Given this list of marker genes PCED1B, HDAC9, ACKR3 (atypical chemokine receptor 3), TRPM8, TRIL, HILPDA, C2orf72, HEXIM1, CAMK2N1, KCNC1, CD24, NANOS1, ARL4D, AMIGO2, FAM83A, WNT11, CHST1, MKNK2, HPX, CRYM, NR2F1, FLRT3, SOX13, FBXO32, ARHGAP15, EFNB2, PLEKHF2, BTG1, PCDH7, ARID5B, DLG2, FZD4, DLX1, EGLN3, here is a description of the gene set: Human Gene Set: LI_ESTROGENE_T47D_E2_RESPONSE_DN from publication Li Z, Li T, Yates ME, Wu Y, Ferber A, Chen L, Brown DD, Carroll JS, Sikora MJ, Tseng GC, Oesterreich S, Lee AV (PMID 37272757) High confident estrogen down-regulated genes exclusively in T47D cells merged from 28 NGS datasets-based comparisons (10% topmost down-regulated genes and consistent in at least 50% comparisons). As one of the most successful cancer therapeutic targets, estrogen receptor-alpha (ER/ESR1) has been extensively studied over the past few decades. Sequencing technological advances have enabled genome-wide analysis of ER action. However, comparison of individual studies is limited by different experimental designs, and few meta-analyses are available. Here, by ingesting large amount of E2-related transcriptomic data sets in breast cancer cell lines, we identified gene expression changes across 66 RNA-seq and 80 microarray experiments based upon the E2-induced fold change in gene expression. MCF7 and T47D cell lines have been used extensively as ER+ breast cancer models. However, extrapolation of this data to breast cancer is complicated by the known heterogeneity of breast cancer and potential biases arising from cell line-specific results. Importantly, while EstroGene contains transcriptomic data from 19 different breast cancer cell lines, data from MCF7 and T47D account for ~50% and ~20%, respectively, of all experiments. To characterize and describe contextual cell-line specific responses, we identified the top 10th percentile of upregulated and downregulated genes in an individual study and consistent among 50% of comparisons within MCF7 or T47D experiments. For non-MCF7/T47D experiments we lowered the threshold to 40% across studies due to the larger heterogeneity in this subset. Intersection of the three subsets yielded 89 and 96 uniquely regulated genes in MCF7 and T47D, we also identified genes that were not regulated in MCF7 and T47D but showed E2-induction in some other cell lines. species: Homo sapiens